The following is a description of a gene set: Eruptive xanthomas are yellow-orange-to-red-brown papules that are often surrounded by an erythematous halo. They appear in crops on the buttocks, extensor surfaces of the extremities, and flexural creases. Acutely, variable amounts of pruritus and pain occur. studied in species Homo sapiens Human Gene Set: HP_ERUPTIVE_XANTHOMAS Eruptive xanthomas, and this is the list of marker genes: APOC2, LIPC, APOE, LPL, GPIHBP1